Given this list of marker genes Gm5691, Gm7289, Gm25005, Cd226, Gm46615, Eif3s6-ps2, Gm25418, Cndp1, Gm7612, Dok6, Gm16146, Gm17266, Gm5826, Gm45871, Gm18280, Gm5824, Gm2390, Gm7623, Gm31621 (predicted gene, 31621), Cndp2, Rttn, Gm24987, Tshz1, Socs6, Gm50401, Gm23859, Gm5234, Gm38576, D030046N08Rik, Cyb5a, Gm5971, Neto1, Gm7662, Ptgr3, Cbln2, Fbxo15, Gm6409, Bhmt1b, Gm20039, Gm31854, Zfp407, Timm21, Mir6359, Dipk1c (divergent protein kinase domain 1C), Gm6173, Tmx3, Gm7674, here is a description of the gene set: species: Mus musculus Mouse Gene Set: chr18E4